Given this list of marker genes Dhx33, Klk5, Ppp1r3f, Nos1, Mfsd9, Ralgapa2, Tbc1d8 (NCBI Gene Id 54610), Dag1, Epb41l1, Cdh8, Vldlr, Klhl41, Dact2, Fbxl14, Azin2, Palm, C2cd2, Mief1, Zzef1, Zfp422, Sec14l1, Ubxn10, Lrrc15, Rpusd3, Grpel2, Gpd2, Wnt9b, Rfng, Arhgap26, AI467606, Zbtb34, Cep72, Igdcc3, Celf5, Gsk3b, Ppt2, Tex13b, Fam168a, Kcnip3, Tmem220 (NCBI Gene Id 338369), Sys1, Tirap, Acrbp (NCBI Gene Id 54137), Fbxl16, Gpr19, Zfp330, Matcap2, Map3k21, Tln1, Ccdc7b, Ralgapa1, Tmem127, Sh3bgr, Tom1, Tfg, Glod5, Atg16l1, Trabd2b, Tmem45a, Bcl2l2, Cbfa2t3, Fgf11, Cherp, Epm2aip1, Stpg1, Tomm34, Iqsec3, Nfasc, Zc3h10, Arpp21, Kcna2, Gpx7, Chrm1, Prx, Tor4a, Gpd1, Cd34, Abcc1, Snph, Ets1, Lrrtm1, Mief2, Fndc7, Atp2b2, Zfp609, Mlxip, Ggt7, Lrrc3, Scd1, Usp2, Ptpn3, Cyb5rl, Bhlhe40, Cnnm1, Prkcb, Slc5a3, Rbbp4, Ces1a, Itga5, Lrtm2, Gata5, Ppp2r5b, Epha3, Rtl5, Mrpl35, Rarres2, Ncan, Acsf2, Kcnip2, Npas3, Zfp362, Tnks2, Lrrc41, Prss35, Rem2, Mtcl2, Rcan2, Cd84, Parva, Erbb4 (erb-b2 receptor tyrosine kinase 4), Zmiz1, Emilin3, Afdn, Grip2, Rnf185, Arhgap32, Metap1, Scfd2, Cpsf7, Mmp13, Fgf18, Dclk2, Bclaf1, Os9, Letm2, Plec, Zfp322a, Scn2b, Pknox2, Arhgap36, Hip1, Alad, Zbtb43, Cd47, Ubiad1, Usb1, Klhl24, Zcchc3, Ccdc127, Wdr76, Dicer1, Glra1, Atf6, Sh2d1b1, Slc35f6, Kif9, Pla2g4f, Fam181b, Abcg1, Rcor1, Nhs, Marchf4, Pou2f1, Plekhd1, Rgma, Slc19a2, Clcn4, Oxsr1, Cables1, Nlk, Brpf3, Cgnl1, Spock1, Ildr2, Phka1, Ucn2, Tspan18, Efna3, Tle1, Homer1, Wnt8b, St8sia1 (ST8 alpha-N-acetyl-neuraminide alpha-2,8-sialyltransferase 1), Tnc, Pla2g4b, Il12rb1, St3gal3 (NCBI Gene Id 20441), here is a description of the gene set: from publication Chen Y, Wang X (PMID 31504780) Genes predicted to be targets of miRBase v22 microRNA mmu_miR_330_5p in miRDB v6.0 with MirTarget v4 prediction scores > 80 (high confidence targets). species: Mus musculus Mouse Gene Set: MIR_330_5P